Given this list of marker genes TBC1D7, MICA, PLA2G5, PISD, RIT1, UBAP1, CXXC5, H2AC4, PSMD14, ZNF830, SPSB1, NIBAN2, JAK3, FAM131A, HELLS, SPAG9, NME7, LRRC52-AS1, SH3GLB1, EYA3, ZFAND3, CD44, RBMX2, TRIM10, H3C8, CCR5, MICALL2, ZFYVE27, SUCNR1, SLC6A1, CD55, CEBPG, UBE2DNL, ATP6V1C1, RAPGEF1, ZNF584, POFUT2, UPP1, FSD1L, UBE2A, BIN3, ATP13A3, CCDC59 (NCBI Gene Id 29080), CDKN1A (cyclin dependent kinase inhibitor 1A), CYTH1, GTF2H4, R3HCC1L, HSPA2, PNLDC1, TSC22D1, COL16A1, LINGO1-AS1, TRIM13, MT1E, CCDC90B, ITGA5 (NCBI Gene Id 3678), LFNG, IL15RA, MIR3976HG, HGS, DENND4A, GTPBP2, TNFSF14, IRX4, RUNX3, MAGOH2P (NCBI Gene Id 548332), PNP, RETREG1, WIZ, RSL24D1, FBXO46, LRWD1, NRCAM, TMEM25, DUSP4, GPR107, TMEM120A, HES4, SMS, FAM78B, NAA11, CSRP2, ATG4D, TOP2A, GLA, HRH1, RAB22A, PSMC3, PSMD11, SLC16A10, GCLM, CREM, FPR1, RPGR, SENP5, PMS2P2, NFE2L2, FAM200A, DENND5A, COL10A1, CASP4, PBDC1, MYBPH, NEK6, ENSG00000215022, DERL2 (NCBI Gene Id 95558, derlin 2), PMPCA, BBIP1 (BBSome interacting protein 1), USP49, IFNAR1, TCF7L2, SYDE2, ANKRD37, CC2D1B, RAPSN, ZNF598, SLC1A2, TXNL1, SERPINB1, LYRM4, RAB40AL, TSPYL6, IGLV1-44, SH2B2, DEXI, IFT57, RRAGA, PIM1, DNAJB12, MS4A14, FBXO42, CD276, PDE7A, ANKRD19P (ankyrin repeat domain 19, pseudogene), ILF2, ANKRD11, ACSL5, RLN3 (relaxin 3), TP53BP2, NCAM1, H3C6, CASP5, BCL2L14, SLAMF7, BTBD19, TMEM88, MB21D2, LAMP3, RGS1, STK10, ARHGEF10L, SLC17A3, MORF4L2, FMNL1, OMD (osteomodulin), ITGAX, PROX1-AS1, IGFBP4, NUP58, PLAC8, ZFAND2B (zinc finger AN1-type containing 2B), GARS1, HIVEP1, OPTN, ETF1, CKAP4, TRIB1, TRA2B, MGLL, CDYL2, SPP1, DLGAP1-AS2 (NCBI Gene Id 84777), CTNNAL1, SLC12A6, HIVEP3, FOXM1, PIR, CDK17, CD2, SOX17, PSMD1, EHD1, SAMSN1, STEAP1B, GPR137B, IAH1, DOCK3, HSPA1A, ORAI1, OR2B2, SLC22A1, UST, MYO1B, ARL8B, FUNDC2, here is a description of the gene set: species: Homo sapiens Gene expression analysis of freshly isolated CD14+ human monocytes and monocytes cultured in the presence or absence of interferon (IFN) -gamma for 24 h and then stimulated with Pam3Cys, a Toll-like receptor (TLR) 2 ligand, for 6 h. Results provide insight into mechanisms by which IFN-gamma reprograms early macrophage differentiation and subsequent response to TLR ligands. Genes down-regulated in comparison of macrophages cultured with M-CSF and IFNG versus macrophages cultured with M-CSF, IFNG and Pam3Cys (TLR2 agonist). from publication Hu X, Chung AY, Wu I, Foldi J, Chen J, Ji JD, Tateya T, Kang YJ, Han J, Gessler M, Kageyama R, Ivashkiv LB (PMID 18976936) Human Gene Set: GSE11864_CSF1_IFNG_VS_CSF1_IFNG_PAM3CYS_IN_MAC_DN